Given this list of marker genes PFKL, DSC1, TREML2, STAT3, SOX4, AHR, PTPN1, HSD11B1, ADAMTSL4, SIPA1L2, TPI1, PGM2, DTL, DTX4, SNX1, FURIN, NT5E, CPNE2, LFNG, SPSB1, HSD17B4, MED22, IL5, HFE, PGAP6, EMILIN2, CCND2, QSOX1, C1RL, ID1, H1-5, CH25H, ETV5, NME4, SAA3P, GAL3ST4, IFITM1, CD163, STING1, GRHPR, SLC39A14, ADORA3, DMPK, SMAD3, C1QB, TNFAIP8, ZDHHC23, PTGFRN, PIK3R2, SLC12A7, SLC16A3 (NCBI Gene Id 9123), CCND1, FCGR2B, LAMA2, NEK6, NFIL3, PDE2A, IL17RA, SLC9A9, APOC2, SLA, STEAP4, P4HA1, PRUNE2, SEMA4C, SFXN5, ABCA1, THBS1, H1-1, CCR2, PIGN, GRINA, EPS8, SLC25A51, KDM7A, ANXA3, HYCC1, CDCA4, NDUFV3, SMAGP, CCR3, SPINK2, TCN2, CD34, FCGRT, MVB12B, CEMIP2, SH2B2, ULK2, IL21R, SEMA6B, KLF7 (NCBI Gene Id 8609), TNFSF14, TBC1D14, NECTIN2, SERPINE2, PGAM1, GAS6, P2RY13, HK2, APOC1, AP2S1, ENPP1, F13A1, ALDOC, PGK1, SBNO2, EDNRA, GALNT2, CD38 (NCBI Gene Id 952), PMEPA1, CHSY1, CALML4, DDIT4, HTR2B, MAFB, NDRG1, SLC39A1, CX3CR1, ARSG, DAP, NAAA, GPR84 (G protein-coupled receptor 84), SSH2, RAB3IL1, SPON1, CD101 (NCBI Gene Id 9398), MCFD2, NOS2 (NCBI Gene Id 4843), CRYL1, LBP, PPP1R3D, KLF2, LDHB, PDK1, STX2, ARHGAP24, PLOD1, EXTL3, OPLAH, RHOH, SESN3, ECM1, PHYHD1 (NCBI Gene Id 254295), MED23, MCM6, CAMKK1, GJA1, TRAPPC14, ITK, PDPN, DEFB103A, PBXIP1, PTPN7, RTN4RL1, TBC1D12, ZC3H12D, ATRNL1, HP (NCBI Gene Id 3240), FLOT1, TMEM9, SOCS3, VGLL4 (vestigial like family member 4), MYD88, CDH1, DHCR24, RUNX3, HOXA2, LRG1, CCR1, SLC2A1, PDE4D, COX7A1, here is a description of the gene set: Human Gene Set: GSE21360_NAIVE_VS_PRIMARY_MEMORY_CD8_TCELL_UP from publication Wirth TC, Xue HH, Rai D, Sabel JT, Bair T, Harty JT, Badovinac VP (PMID 20619696) studied in species Homo sapiens Genes up-regulated in CD8 T cells: naïve versus 1' memory. The transcriptome of naive OT-I T cells was compared to memory CD8 T cells after 1, 2, 3, or 4 infection with ovalbumin expressing Listeria monocytogenes (LM-OVA).